Given this list of marker genes SF3B3, MDK, TENT5A, HSPA1B, IGFBP6, GRN, PCDHGC3, EEF1AKMT3, RAC2, MAFF, ATP7A, FTH1 (ferritin heavy chain 1), ADIRF, LZTFL1, JUP (junction plakoglobin), ZDHHC3, AHNAK2, CDKN1A, DALRD3, IER5, TFPI, here is a description of the gene set: studied in species Homo sapiens Genes up-regulated in gastric cancer cell lines resistant to cisplatin. Human Gene Set: KANG_CISPLATIN_RESISTANCE_UP PURPOSE: A major obstacle in chemotherapy is treatment failure due to anticancer drug resistance. The emergence of acquired resistance results from host factors and genetic or epigenetic changes in the cancer cells. The purpose of this study was to identify differentially expressed genes associated with acquisition of resistance in human gastric cancer cells. EXPERIMENTAL DESIGN: We performed global gene expression analysis in the acquired drug-resistant gastric cancer cell lines to the commonly used drugs 5-fluorouracil, doxorubicin, and cisplatin using Affymetrix HG-U133A microarray. The gene expression patterns of 10 chemoresistant gastric cancer cell lines were compared with those of four parent cell lines using fold-change and Wilcoxon's test for data analysis. RESULTS: We identified over genes differentially expressed in 5-fluorouracil-, cisplatin-, or doxorubicin-resistant gastric cancer cell lines. Our expression analysis also identified eight multidrug resistance candidate genes that were associated with resistance to two or more of the tested chemotherapeutic agents. Among these, midkine (MDK), a heparin-binding growth factor, was overexpressed in all drug-resistant cell lines, strongly suggesting that MDK might contribute to multidrug resistance in gastric cancer cells. CONCLUSIONS: Our investigation provides comprehensive gene information associated with acquired resistance to anticancer drugs in gastric cancer cells and a basis for additional functional studies. from publication Kang HC, Kim IJ, Park JH, Shin Y, Ku JL, Jung MS, Yoo BC, Kim HK, Park JG (PMID 14734480)